Given this list of marker genes PLCB1, WNT3A, CFL1, OSR1, OTX2, WNT1, FOXA2, NLRP5, LHX1, TENM4, NR2C2, UTP25, AMOT, RACK1, TLE6, ZBED3, PAFAH1B1, SCX, RBM19, B4GALT5, KHDC3L, WNT4, here is a description of the gene set: studied in species Homo sapiens Any process that activates or increases the frequency, rate or extent of embryonic development. Human Gene Set: GOBP_POSITIVE_REGULATION_OF_EMBRYONIC_DEVELOPMENT